The following is a description of a gene set: studied in species Mus musculus Any process that modulates the frequency, rate or extent of telomere capping. Mouse Gene Set: GOBP_REGULATION_OF_TELOMERE_CAPPING, and this is the list of marker genes: Hnrnpd, Mapkapk5, Nek2 (NCBI Gene Id 98226), Terf2, Smg6, Potefam3a, Mapk1 (NCBI Gene Id 98012), Tnks2, Aurkb, Ercc1, Mapk3, Nbn, Atm, Xrcc1, Ercc4, Rad50, Nek7, Potefam3b, Nabp2, Ankrd66, Pkib, Prkcq, Xrcc4, Pnkp, Map2k7, Mapk15, Rtel1, Tnks, Map3k4 (mitogen-activated protein kinase kinase kinase 4)